Given this list of marker genes LDLR, LIPC (NCBI Gene Id 3990), LDLRAP1, APOB, APOE, here is a description of the gene set: Human Gene Set: REACTOME_CHYLOMICRON_CLEARANCE studied in species Homo sapiens Chylomicron clearance